The following is a description of a gene set: In addition to protein coding mRNAs and stable RNAs such as rRNAs, tRNAs, snoRNAs, and snRNAs, the human genome is pervasively transcribed to yield other non-coding RNAs such as enhancer transcripts, promoter upstream transcripts (PROMPTs, Preker et al. 2008), long non-coding RNAs (lncRNAs), and apparently non-functional transcripts. In addition, processing intermediates and abortive transcripts are produced during transcription of mRNAs and stable RNAs. In the nucleus, pervasive unstable transcripts are degraded by nucleases such as the RNA exosome complex (a 3'-5' exonuclease), XRN2 (a 5'-3' exonuclease), and DXO (a 5'-3' exonuclease and a decapping enzyme). RNA substrates are directed to the RNA exosome by the nuclear exosome targeting (NEXT) complex, the poly(A) tail exosome targeting (PAXT) connection, and the Trf4/5-Air1/2-Mtr4 polyadenylation (TRAMP) complex. This sorting is crucial to the removal of malformed transcripts and misassembled RNA-protein complexes. Through ZC3H18 or ZC3H4, the NEXT complex (RBM7:ZCCHC8:MTREX) binds capped nonpolyadenylated RNAs, such as abortive transcripts from RNA polymerase II, recruits the RNA exosome, then the MTREX (MTR4, SKIV2L2) subunit of NEXT unwinds the RNA for introduction into the barrel-shaped RNA exosome. The PAXT connection (ZFC3H1:MTREX) targets more mature, capped and polyadenylated transcripts, and the nucleolar TRAMP complex (MTREX:TENT4A,B:ZCCHC7) targets processing products of rRNA maturation. The 5'-3' exonuclease XRN2 is active on RNAs that possess a 5' monophosphate group (inferred from the yeast homolog in Stevens and Poole 1995), but is blocked by a 5' triphosphate or cap structure. Substrates of XRN2 include decapped RNAs and the 3' cleavage products of RNA polymerase II transcripts. The decapping 5'-3 exonuclease DXO can both remove 5' triphosphate or caps (especially unmethylated caps) and exonucleolytically hydrolyze RNAs. DXO is also active on nicotinamide adenine dinucleotide (NAD) cap on RNAs and other "metabolic caps" (several activities and references can be added here, see below). The exonuclease activity of DXO is distributive, while that for XRN2 is processive. The human TRAMP complex is found in a complex with the RNA exosome in the nucleolus where it directs the 5' external transcribed sequence that is cleaved from the 47S pre-rRNA during production of the 45S pre-rRNA. studied in species Homo sapiens Reactome Pathway: Nuclear RNA decay part of: Metabolism of RNA, and this is the list of marker genes: EXOSC7, DIS3, WDR82, NCBP2, MPHOSPH6, MTREX, EXOSC9, DXO, EXOSC3, XRN2, EXOSC1, PABPN1, TENT4A, YTHDC2, EXOSC10, EXOSC4, SRRT, RBM27, C1D, TENT4B, YTHDC1, EXOSC8, RBM26, PAPOLG, ZCCHC7, RBM7, EXOSC5, EXOSC6, ZCCHC8, EXOSC2 (exosome component 2), ZC3H3, NCBP1, ZFC3H1, ZC3H18, ZC3H4